The following is a description of a gene set: Pendular nystagmus Rhythmic, involuntary sinusoidal oscillations of one or both eyes. The waveform of pendular nystagmus may occur in any direction. studied in species Homo sapiens Human Gene Set: HP_PENDULAR_NYSTAGMUS, and this is the list of marker genes: TMEM63A, NT5C2, RPGR, PPOX, CNGA3, AIPL1, NUP54, CRX, RARS1, CLTCL1, SCN1A, CNGB3, BLOC1S3, PLA2G6, ATP1A2, TENM3, TMEM106B, P4HTM, CNNM4, CACNA1A, PDE6H, DLAT, NUP62, SDHD, TBL1XR1, RPGRIP1, OPN1MW, ADAR, OPN1SW, PEX2, DNMBP, ATOH7, HMGB3, CARS1, PDE6C, MT-ATP6, FRMD7 (NCBI Gene Id 90167), GNAT2, OPN1LW, ARHGEF2, GFAP, PRRT2, PLP1, LRP5, ATF6